The following is a description of a gene set: Mouse Gene Set: GOMF_MINOR_GROOVE_OF_ADENINE_THYMINE_RICH_DNA_BINDING Binding to a DNA structure formed by the minor groove of adenine-thymine-rich DNA regions. Examples of proteins having this function are AT-rich interaction domain (ARID)-containing proteins. species: Mus musculus, and this is the list of marker genes: Hand2, Mef2c, Tcf20, H1f0, Pou3f4, Lin54, Hmga1, Pax6, Hmga1b, Hnrnpd, Hmga2